The following is a description of a gene set: Human Gene Set: MOHANKUMAR_HOXA1_TARGETS_UP from publication Mohankumar KM, Xu XQ, Zhu T, Kannan N, Miller LD, Liu ET, Gluckman PD, Sukumar S, Emerald BS, Lobie PE (PMID 17213808) Up-regulated in MCF7 cells (breast cancer) by HOXA1. Expression of homeobox A1 (HOXA1) results in oncogenic transformation of immortalized human mammary epithelial cells with aggressive tumor formation in vivo. However, the mechanisms by which HOXA1 mediates oncogenic transformation is not well defined. To identify molecules that could potentially be involved in HOXA1-mediated oncogenic transformation, microarray analysis was utilized to characterize and compare the gene expression pattern in response to forced expression or depletion of HOXA1 in human mammary carcinoma cells. Gene expression profiling identified that genes involved in the p44/42 mitogen-activated protein (MAP) kinase activation pathway (GRB2, MAP kinase kinase (MEK1) and SDFR1) or p44/42 MAP kinase-regulated genes (IER3, EPAS1, PCNA and catalase) are downstream expression targets of HOXA1. Forced expression of HOXA1 increased GRB2 and MEK1 mRNA and protein expression and increased p44/42 MAP kinase phosphorylation, activity and Elk-1-mediated transcription. Use of a MEK1 inhibitor demonstrated that increased p44/42 MAP kinase activity is required for the HOXA1-mediated increase in cell proliferation, survival, oncogenicity and oncogenic transformation. Thus, modulation of the p44/42 MAP kinase pathway is one mechanism by which HOXA1 mediates oncogenic transformation of the human mammary epithelial cell. studied in species Homo sapiens, and this is the list of marker genes: KRT38, PGD, CRABP2, ALG8, CDH3, CAPN15, RBM47, CPE, COPS4, VTCN1, ADIPOR1, PRLR, TIMP3, RAE1, TFPI, THAP12, NAA50, CCT6A, SKI, ARPC1B, AP1M2, DPP3, HNRNPLL, PPT1, TTC39A, CYB5B, PLK1, GRB2, HSPA8, MEST (NCBI Gene Id 95680), BCAT2, UBE2E1, IER3, DDX1, HSPA14, DERPC (NCBI Gene Id 113455421), SEZ6L2, MMGT1, RHOB, TXNDC11, CAPN1, SGCG, USP5, SULF1, RRM1, PPM1D, HSP90B1, ISG20L2, GDAP1, DDX6, CACNA2D4, GLG1, CARM1, MAT2A, FUT8, COPS8, CLN6, ENOPH1, PALLD, CD36, PLK2, UBL3, HOXC6, LDHA, DUSP14, LDHB, TRAF4, OSBPL9, TM9SF2, ASF1B, LITAF, GINS3, RAD51C, CYP1A1, EIF5, SEMA4C, CCNB2, EEF1A1, CAT, TTC3, PPAN, GTF2I, SRSF1, UBE2K, SEPHS2, CLDN7, CRAMP1, CNTLN, PDZK1, ATP2B1, UFD1, VPS4A, PGM2, TMED2, TFAP2A, NAALADL2, CDC20, TTC27, CPT2, CNNM4, MEMO1, ST3GAL4, XPO1, LPIN1, PLAC4, ARRB1, MSH2, HADHB, RCC1, KLK4, BHLHE40, HNRNPK, WSB2, GNL2, RBMY3AP, MORF4L2, IARS2, PRCP, PRUNE1, HMBS, UBE2D3, LAMB2, KCNJ3, CLU, PBX1, PAICS, WEE1, SULF2 (sulfatase 2, NCBI Gene Id 55959), H1-0, SYT12, HNRNPM, FRMD4A, NPTN, SEPTIN2, DCTN1, MRPS35, RNF139, ZNF207, PRKDC, HIBADH, BCKDK, TSKU, FUS, ILF3, HELLS, NOP2, PSMB5, GPAT4, NSD3, SLC35B1, ANGPTL1, ANP32E, CDC42EP2, ATXN10, NTRK3, PPP2R1A, PIGK, UBFD1, SHCBP1, TBRG4, SLC44A1, ADCY5, BAMBI, CAMK2B, ILRUN, NOTCH2NLA, RB1, KPNA2, PCLAF, DDAH1, SF3B3, ADNP, ACADVL, BUB1, E2F7, FAT1, PHKG2, PADI2, CA12, EIF4G2, E2F4, ACTL6A, ZNF839, SPAG5, SQSTM1, LINC00474, CDK1, SEPTIN7, HOMER1, ACKR3, SPG21, HELZ, CHN1, HIPK1, AR, ASB13, FBXO10, UNC119B, MTHFD1, ARF3, LARGE1, ZFAND6, TAOK2, ATP1B3, PCDH19, SCNN1A, EIF4H, TBX21, LRRTM4, GALNT6, PPP1CB, PLBD1, BAHCC1, LRRC59, TMEM38A, INTS13, KYNU, PHTF1, METTL14, PRRC2A, MBOAT7, STK26, CDC25A, MED13L, DDIAS, YME1L1, ELOVL5, ABCD3, LRP8, PTGFRN, EEIG2, AMD1, QPRT, GCA, OAT, CMTM6, CERS6, IDH3A, WDR46, NXPH3, PSMD13 (NCBI Gene Id 5719), SLC20A1, CCDC71 (coiled-coil domain containing 71), RHOQ, BZW2, GLB1, SELENOT, PARL (NCBI Gene Id 55486), ALKBH5, RPN2, RRM2, NOLC1, CDK2, KLK12, L1CAM, PPP1CC, DCAF7, HTATIP2 (HIV-1 Tat interactive protein 2), MRTFB, ADAMTS9, GPN3, RPA1, PRMT1, RPRD2, CORO1B, RFC5, IRX5, TRAP1, TUBA1C, PKP4, TFAP4, CALR, SEMA3B (semaphorin 3B), CCDC47, NUP210, TSPAN5, PPFIA1, RITA1, SRPRA, SMG7 (SMG7 nonsense mediated mRNA decay factor), G6PD, OGFOD1, DNAJB1, UBE2L6, PTP4A1 (protein tyrosine phosphatase 4A1), POLA2, B4GAT1, G0S2, CENPT (centromere protein T), CASP2, PKM, GSKIP, TIMM17A, PLAAT3, CLPTM1, H2AX, TUBB, ABTB2, RBMS2, CORO1C, CTSD, ARCN1 (NCBI Gene Id 372), TGIF2, NKAIN1, ICMT, PAPSS1, FANCC, PFKM, H4C14, HOOK1, GAL, CDYL2, ARMT1, ZNF600, UNC5C, PNPLA3, EPB41L5, COPB2, GTF2H1, SIAH2, ZMIZ1, NUTF2, PGRMC1, NGRN, UGP2, MARCKSL1, TOMM40, SYNPO2, MAZ, LXN, NCAM2, IFITM10, GSE1, SNX27, LHX1, LIN7A, GATA4, ZWILCH (NCBI Gene Id 55055), MTF2, ADAR, CELF1, ATP6AP1, ZNF583, CS, DHRS2, CLN8, ALDH3A2, SEC63, RGS16, NDC1, DNAJA3, HSPA1B, KCTD3, CHKA, TMEM94, PLPP2, ZWINT, GLA, RPS4X, CCT8, GET1, RNF10, COPB1, PCNA, PICALM, ZMPSTE24, SLC39A8, MAP2K1, ITPK1, TUBB4B, ELOVL2, TATDN2, RAB6A, ATXN1L, PRDX3, HOXD9, ELAVL1, RAB1B, SMN1, HSD17B4, KCNK2, CCN5, YAF2, EPAS1, UQCRC1, BCL2L11, PHKB, CHD8, DYNC1LI2, MCM3, NUP93, MDC1, PLEKHO1, HSPB8, GSTM3, RUVBL1, PSMD6, ANAPC5, CDC6, SORL1, SEC24D, FARSB, WDR77, PIP4K2A, MEPCE, MOGS, GNAS, DNMT1, GATM, H1-2